Given this list of marker genes CYB5A, LAMP1, HLF (HLF transcription factor, PAR bZIP family member), SLC40A1, MAP4K2, EDEM2, SPOP, VTA1, POLD3, CXXC5, NAAA, AURKA, TPX2, PCGF2, APPBP2, DLGAP5, PMEPA1, GSDMB, MSX2, FADS2, BDH1, DECR1, UMPS, PRIM1, TOMM34, POLR2K, GSS, SIAH2, UCP3, COX11, LRRC3, GPR160, CDCA5, PFDN4, STK4, MMP16, UBE2Z, PIP4K2B, RAB24, BRINP2, NPY1R, FAM168A, TFAP2C (NCBI Gene Id 7022), TP53INP2, SEMA4D, PDK2, SCGB2A2 (NCBI Gene Id 5661, secretoglobin family 2A member 2), CCNG2, RBM38, MRPL48, CYP1A1, NCOA3, MED24 (mediator complex subunit 24), here is a description of the gene set: Human Gene Set: MODULE_325 studied in species Homo sapiens Genes in the cancer module 325.